Given this list of marker genes Adgrv1, Bbs4, Cdhr1, Esrrb, Cln8 (NCBI Gene Id 26889), Ercc6, Iqcb1, Lca5, Rho, Abca4, Wdr36, Slc2a1, Mak, Nphp3, Usp45, Tub, Epg5 (NCBI Gene Id 71423), Pde6a, Tulp1, Gnat2, Sod1, Pcdh15, Cdh23, Vstm4, Ush1g, Atp1b2, Nxnl2, Nphp4, Spata7, Crb1, Ush2a, Poc1b, Bbs12, Whrn, Mkks, Crocc, Map1a, Cep290, Cngb1, Aipl1, Slc28a2, Ccdc66, Prom1, Cib2, Rp1l1, Bbs10, Slc28a3, Arap1, Ndp, Crb2, Nxnl1, Elp6, Clcn3, Slc28a2b (solute carrier family 28 member 2b), Clrn1 (clarin 1), Bbs2, Rpe65, Rp1, Dram2, Cdh3, Bbs1, Ush1c, Vhl, Bsg, here is a description of the gene set: Mouse Gene Set: GOBP_RETINA_HOMEOSTASIS species: Mus musculus A tissue homeostatic process involved in the maintenance of an internal equilibrium within the retina of the eye, including control of cellular proliferation and death and control of metabolic function.